The following is a description of a gene set: Human Gene Set: GOBP_RENAL_SYSTEM_PROCESS An organ system process carried out by any of the organs or tissues of the renal system. The renal system maintains fluid balance, and contributes to electrolyte balance, acid/base balance, and disposal of nitrogenous waste products. In humans, the renal system comprises a pair of kidneys, a pair of ureters, urinary bladder, urethra, sphincter muscle and associated blood vessels; in other species, the renal system may comprise related structures (e.g., nephrocytes and malpighian tubules in Drosophila). species: Homo sapiens, and this is the list of marker genes: HNF1A, TACR1, CLDN19, ADCY6, NPR3, SULF1, TTR, AVPR2, CHRNA3, KCNJ1, AQP3, CLCNKB, SLC15A2, NPHS2, CORO2B, GSN, CYBA, COMT, ADORA2A, CHRNA7, BCR, CLCN5, PRKACA, IGKV3-20, OXSR1 (oxidative stress responsive kinase 1), JCHAIN, IGHA1, SLC4A5, AQP4, KLHL3, RHPN2, SLC6A18, TMEM63C, CYP4A11, BTC, MYO1E, EDN1, SLC25A23, CHRNB4, F2RL1, CYP4F12, PCSK5, WFS1, ABCG2, NHERF1, SPX, MRGPRD, SLC5A2, MAGED2, BMP4, PON3, KCNMA1, KIRREL1, SLC22A6, CYP4F2, BCL2, GUCA2B, AGT, ADORA1 (NCBI Gene Id 134), CLCNKA, HAS2 (NCBI Gene Id 3037), AKAP11, WNK4, EDNRB, SLC4A1, NPR1, ADIPOQ, AQP1, CD34, TBC1D8B, PRKACB, SLC22A12, CLDN16, TRPV1, AGTR2, STC1, UMOD, CD2AP, CHRNB2, GJA5, SCN11A, SLC5A1, XPNPEP3 (X-prolyl aminopeptidase 3), RRM2B, PDGFB, PKN1, AGTR1, OR51E2, AQP6, REN, F2R, CLN3, HYAL2, ATP6V0A4, ATP6V1B1, OXT, MCAM, SULF2, AKR1C3, HSD11B2, LGMN, NPPB, AMN, KCNQ1, CYP11B2, MAS1, EMP2, CORIN, SGK1, PRKRIP1, OIT3, SUCNR1, GNAS, AKR1B1, SERPINF2, AQP2, PTPRO, EDNRA, DRD2, GAS6, ADGRF5, INPP5K, WNK3, IGHA2, ITGA3, STK39 (NCBI Gene Id 27347), SLC12A3, PRKACG, PPP3CA (NCBI Gene Id 5530), GNAI2, MYO5B, TRPV5, RHOA, MLLT6, ADM, CLDN4, SCNN1B, HBB